Given this list of marker genes PMFBP1, SUN5, BRDT, TSGA10, SPACA1, ACTL7A, CEP112, here is a description of the gene set: Spermatozoa with very small cranial ends devoid of any nuclear material, that is, lacking a typical sperm head. Acephalic spermatozoa studied in species Homo sapiens Human Gene Set: HP_ACEPHALIC_SPERMATOZOA